The following is a description of a gene set: Mouse Gene Set: GOBP_NEGATIVE_REGULATION_OF_INTERLEUKIN_1_PRODUCTION Any process that stops, prevents, or reduces the frequency, rate, or extent of interleukin-1 production. species: Mus musculus, and this is the list of marker genes: Gstp1, Ffar1, Ceacam1, Pml, Cx3cl1, Zc3h12a, Nlrp12, Gstp2, Nlrc3, Chrna7, Acp5 (acid phosphatase 5, tartrate resistant), Serpinb1b, Ghsr, Cptp, Il1r2, Git1, Errfi1, Rad21, Apoa1, Gas6, Ffar4, Nlrp3, Ghrl, Hdac3, Aqp4, Gstp3, Cx3cr1, Nr1h4, Tnfaip3, Trem2, Igf1, Spag11a, Lilrb4b, Mefv, Arrb2, Serpinb1c, Ptger4, Lilrb4a, Gstp-ps, Elf4, Serpinb1a